The following is a description of a gene set: Human Gene Set: MIR1_5P Genes predicted to be targets of miRBase v22 microRNA hsa-miR-1-5p in miRDB v6.0 with MirTarget v4 prediction scores > 80 (high confidence targets). from publication Chen Y, Wang X (PMID 31504780) studied in species Homo sapiens, and this is the list of marker genes: TRPC3, ERRFI1, SLC25A40, TGIF1, TMEM242, PDHX, MAPK8, YTHDC1, MYBL1, CAND1, ZC3H4, BICD1, ZMYM5, KDM6A, ASPN, SREK1, VPS54 (VPS54 subunit of GARP complex), VPS13D, VCL, UHMK1, ARID1A, RPS6KA5, AURKA, PWP1 (NCBI Gene Id 11137), PROX2, THOC7, FNIP1, STK17B, ERAP1, FBXO45, CDH19, XKR4, FUCA1, C1orf94, PSMA2, ZNF567 (zinc finger protein 567), AHR, NUDCD2, DENND1B, CYP7A1, BORA, SNTB1, FAM162A, UCHL5, TRIM6, RP1, MAP3K8, FAM81A, ELAPOR2, DTL, SRSF6, CTNNA2, CNOT6L, GNPAT, ANKRD27, FUT9 (NCBI Gene Id 10690), PRPF39, GRHL1, SLC40A1, FOXO3, PAG1, PYGO1, CSMD3, PHLDB2, TACC1, DGKH, CISD3, DMXL1, CFAP20DC, SNX6, FEZ2, TMEM192, HIKESHI, DAB2IP, CLDND1, PAIP2B, KIAA0825, N4BP2, LSM8, TSC22D2, ZNF677, UGCG, MSI2, SSR3 (NCBI Gene Id 6747), TSHZ1, ATF2